The following is a description of a gene set: electronically inferred by orthology from the curated human pathway This event has been computationally inferred from an event that has been demonstrated in another species.<p>The inference is based on the homology mapping from PANTHER. Briefly, reactions for which all involved PhysicalEntities (in input, output and catalyst) have a mapped orthologue/paralogue (for complexes at least 75% of components must have a mapping) are inferred to the other species. part of: Xenobiotics studied in species Mus musculus Reactome Pathway: CYP2E1 reactions, and this is the list of marker genes: Cyp2c65, Cyp2c66, Cyp2e1, Cyp2d22, Cyp2a12, Cyp2a4, Cyp2f2